The following is a description of a gene set: from publication Schaefer CF, Anthony K, Krupa S, Buchoff J, Day M, Hannay T, Buetow KH (PMID 18832364) Human Gene Set: PID_FANCONI_PATHWAY Fanconi anemia pathway species: Homo sapiens, and this is the list of marker genes: ATM, SSPOP (SCO-spondin, pseudogene), FANCG, RAD50, RFC2, ATR, FANCI, RPA2, FAAP100, FAN1, FANCE, MRE11, ATRIP, H2AX, FANCA, CENPS, USP1, RFC4, RFC5, TOPBP1, RMI1, TOP3A, RAD1, FANCL, RPA1, FBXW11, FANCM, NBN, RAD9A (RAD9 checkpoint clamp component A), HUS1, RFC3, RAD17, CHEK1, FANCC, WDR48, FAAP24, FANCF, BRCA1, PALB2, BRIP1, UBE2T, BLM, XRCC3, BRCA2, HES1 (NCBI Gene Id 3280), FANCB, FANCD2